Given this list of marker genes SOX5, CD99L2, CD274, BRSK1, SUSD4, IFI44L, CCDC28B, TJP3, TCIM (NCBI Gene Id 56892), RAD51B, SPARCL1, RP2, RPL10, DNALI1, ADCY6, ASB7, CHRNB4, G0S2, FBXO16, GNG2, REM2, TUT1, DRC3, MOSPD1, LRRC4B, TOMM40L, CTNND1, HRAS, CNTNAP1, COX6A2, GAB3, FBXW7, FTSJ1, SLC26A7, FNDC11, MPST, MCTS1 (NCBI Gene Id 28985), SRPK2, WDCP, LYSMD4, PBXIP1, PLAT, LRRN3, KLHL5, PBX1, HSD17B11, B3GALT2, COL4A5, OSBPL7, TCEAL8, MEAK7, DPP7, PABIR2, TMEM242, GPX8, MMACHC, PDE4B, RAB13, TCTN2, WASHC3, ASB15, RDH11, SLC7A11, FASTKD1, NAV3, SUMF2, PCDHB13, ANGPT2, TGFB3, ZNF646, LY96, ADAMTS12, ZNF595, PPP2R5C, BPGM, KCND2, GCDH, CCDC77, AK1, RIOK2, IRGM, ZNF354B, RFX5, PDE1A (phosphodiesterase 1A), CNTN6, LRRTM3, FUNDC2, NXPE4, CWF19L2, TMEM256, SLITRK1, ZIK1, CNPY4, CDHR4, NOP10, SAT2, MT3, TLR2, CC2D2A, INHA, PTN, MED24, GTF2H4, VPS50, TRIM16, ATP5MC1, RCOR2, RBM41, DGKB, ZMAT5, TFPT, SEMA3A, TSNAXIP1, PPP2R3C, POLR2K, ALG3, SPARC, LAMB2, DDR2, CBLN3, FERRY3, APOOL, CAMK1, AXL, FRMD4A, GRM3, KLC4, SAP30BP, GOSR1, DUSP19, CHAC2, C5orf34, GABRG1, PRPF31, ABCA9, KIF14, ACY1, DTNA, CLEC2D, NME7, SLC12A6, NEIL1, FASTKD2, LRP1, YPEL4, HDAC9, CSTPP1, GHDC, SPRED3, SCNM1, CORO1A, DNASE1L1, CLIC1, PRRC2A, PRCP, DNAJC12, HSPB6, EOLA1, ACSBG1, TMEM35A, TSPAN11, KCNJ2, ZNF276, WDR24, NUDT13, FLRT3, LYSMD1, MRPL35, GRIK5, NSUN6, HMG20A, GRN, STOML1, CAPN1, SLITRK6, NMRAL1, ITM2A, ZEB2, GOLPH3L, GEMIN6, LSG1, TCAF1, MAPK10, DENND2B, FAS, ZNF454, VPS41, RPL19, TMEM100, RBMS2, GPM6A, LIN52, ZNF708, TTC23, SSPN, TRAPPC14, LPAR6, ATG4A, ZFYVE26, USP49, SMIM26, WDR12, HYAL1, TRAK1, ZNF429, EMP1, CDH10, PAFAH2, SYNJ2, C8orf48, PCDHB2, BCHE, PLPP7, ATXN7L1, RIN2, AKR1B10, MBNL2, TBC1D22B, CSRNP3, GALE, LASP1NB, TRAPPC13, KCTD20, NCKAP5, APOBEC3B, ZNF112, FLAD1, TBKBP1, TRIM46, ARHGAP18, ADD3, ZNF607, DGLUCY, SLC38A7, CTNS, ATP13A4, CYB5R2, VGLL4, P2RX7, ACTN3, TIMM21, POLD4, SFXN3, ZC3HC1, WDR83OS, ARHGEF9, SPSB3, DNAI3, TKFC, SLC9A9, TTLL9, KATNAL2, CCDC39, H1-6, TLK2, WBP1L, TMEM198B, PYCR1, GPER1, INTS9, FIS1, IKZF2, ETFBKMT, RBBP9, RAD54L, TOR1AIP2, ZBTB18, TCN2, ZSWIM9, DNAJC4, LPAR4, MEGF10, SYN3, WDR38 (WD repeat domain 38), ALOXE3, IDNK, OSGEPL1, HMMR, TPCN2, ABCA8, ZMYND8, S100B (S100 calcium binding protein B), LOXL3, NUDT22, EHBP1, A2M, RBMS3, PRR11, NRXN1, TMEM67, TPP1, IFT56, ABCD2, CFAP52, TNFAIP6, CALD1, GMPPA, LIPA, FAM222B, STC1, FAM3A, CA3, ADAMTS6, CAVIN2, BLZF1, SYT1, ZFP82, ADAMTS4 (ADAM metallopeptidase with thrombospondin type 1 motif 4), RBM4, MRGPRE, TXLNB, FRG2B, PCDH9, ALDOC, CDKN2C, ZNF317, LRRC4C, SH3BGRL, FAM13A, NOSIP, LIMA1, ERICH6, NQO1, PLD1, SLC15A2, ZC4H2 (NCBI Gene Id 7493), BAK1, FBP2, DLG4, LIX1, ECH1, BIVM, FKBP7, MDH1B, MGST1, DYNC2LI1, BBS1, ATOSA, TRMT10B, SYT3, PDE1C (NCBI Gene Id 5137), GSTM2, MAPDA, ZNF608, IFTAP (intraflagellar transport associated protein), LRRTM2, THBS3, METTL15, NOL4, ARMH4, SUPT7L, GAP43, IFITM2, HDAC6 (NCBI Gene Id 100820762), ENTPD1, EXTL1, MPI, ZKSCAN5, ADHFE1, BCL2L2, MTCL3, CTU1, PANK1, PRIM1, CLCN5, SLC37A4, RAI14, RAPGEF3, GPR183, TMEM69, ZRANB3, ZNF239, DYNLRB2, ZNF235, AKAP7, SCRG1, CD44, VCAM1, ZSWIM2, CPT1C, NCAN, ANGPT1, PCLAF (NCBI Gene Id 9768), MRTFB, ZNF182, PUS3, BMERB1, NDP, RFTN2 (NCBI Gene Id 130132), RUFY3, SRGAP3, GSTM5, SMARCAL1, ETV1, DECR2, ANK2, ENTREP3, COL1A1, AADAT, ACTR6, SMUG1, IFIT2, ZNF585B, MPV17, CCDC141, SIPA1, EXOC4, KDM6B, FKBP14, DCLRE1C, SERINC4, SERPINI1, CREB5, PPARGC1A, MTERF2, TMEM14A, CPEB4, FAM111A, PHKG2, FUNDC1, NICN1, RTTN, HSPA1L, AGPAT4, ZNF260, NIF3L1, ATP6V1G2, PCDHB4, ALKBH8, CCDC93, IGBP1, RECQL5, AKR1E2, FRRS1, NOL8, PLIN2, CTSO, DYNLT3, DCLRE1A, RHOJ, AOX1, PCYT1B, CHM, PTER, LARS1, KCNA4, PML, here is a description of the gene set: Genes with intermediate-CpG-density promoters (ICP) bearing histone H3 trimethylation mark at K4 (H3K4me3) in neural progenitor cells (NPC). Human Gene Set: MIKKELSEN_NPC_ICP_WITH_H3K4ME3 We report the application of single-molecule-based sequencing technology for high-throughput profiling of histone modifications in mammalian cells. By obtaining over four billion bases of sequence from chromatin immunoprecipitated DNA, we generated genome-wide chromatin-state maps of mouse embryonic stem cells, neural progenitor cells and embryonic fibroblasts. We find that lysine 4 and lysine 27 trimethylation effectively discriminates genes that are expressed, poised for expression, or stably repressed, and therefore reflect cell state and lineage potential. Lysine 36 trimethylation marks primary coding and non-coding transcripts, facilitating gene annotation. Trimethylation of lysine 9 and lysine 20 is detected at satellite, telomeric and active long-terminal repeats, and can spread into proximal unique sequences. Lysine 4 and lysine 9 trimethylation marks imprinting control regions. Finally, we show that chromatin state can be read in an allele-specific manner by using single nucleotide polymorphisms. This study provides a framework for the application of comprehensive chromatin profiling towards characterization of diverse mammalian cell populations. from publication Mikkelsen TS, Ku M, Jaffe DB, Issac B, Lieberman E, Giannoukos G, Alvarez P, Brockman W, Kim TK, Koche RP, Lee W, Mendenhall E, O'Donovan A, Presser A, Russ C, Xie X, Meissner A, Wernig M, Jaenisch R, Nusbaum C, Lander ES, Bernstein BE (PMID 17603471) studied in species Mus musculus